The following is a description of a gene set: Any process that modulates the frequency, rate or extent of a protein or other molecule binding to a receptor. studied in species Homo sapiens Human Gene Set: GOBP_REGULATION_OF_RECEPTOR_BINDING, and this is the list of marker genes: GREM2, ADIPOQ, MIR148A, MIR27B, BDNF, ADAM15, IL10, MMP9, PTPRF